Given this list of marker genes Tmem147 (transmembrane protein 147), Nomo1, Ccdc47, Tmco1, Rab5if, Wdr83os, Ncln, here is a description of the gene set: Mouse Gene Set: GOCC_MULTI_PASS_TRANSLOCON_COMPLEX A protein complex that mediates the insertion of multi-pass transmembrane proteins into endoplasmic reticulum (ER) membrane. Substrates enter via the lateral gate of the Sec61 translocon. The complex comprises the GEL subcomplex (composed of RAB5IF/OPTI and TMCO1), the BOS subcomplex (composed of NCLN/Nicalin, NOMO and TMEM147) and the PAT subcomplex (composed of WDR83OS/Asterix and CCDC47). studied in species Mus musculus